Given this list of marker genes PSMB2, PAN3, BIRC6, TLR7, RANBP1, METTL15, H2AX, FRMD6, PIK3R5, SEMA4C, EZH2, ESCO2, LARP7, TBC1D32, ESYT3, SNX5, TCF4 (transcription factor 4), CA9, ZNF326, LSM6, MXD3, CBX2, FHOD3, TRIO, ERCC6L, SPC24, KCTD8, NSMCE1, GRIA2, N6AMT1, CDC25B, PSPH, DNMT3B, FGA, DLX1, NEK6, PADI4, RAC2, MAP7D1, NUTF2, CIT, MSRA, SLC25A39, RCSD1, LRRC40, ATXN10, SEMA3D, C4orf19, GALR1, HSD11B1, RASA4, RNF144A, MPEG1, RASA2, CD52, KPNA7, HLA-DMA, PRKDC, HMCES, OTOG, ITGB1BP2, SLCO3A1, SLFN5, ING3, POC1B, ANAPC15, BAIAP2, DHRS3, KNL1, IPCEF1, CASQ2, SLC9A9, CDK13, UMPS, GMIP, NTPCR, GAB3, CHRNA6, PYCARD, CTSS, TNFAIP1, ITGAL (integrin subunit alpha L), HYOU1, NPTXR (NCBI Gene Id 23467), ICOS, ELF3, C3orf52, MGAT5, MSRB3, PDGFRB, RAC3, SF3B4, STMN1, CEP72, SELPLG, TXNDC8, CENPN, MORN2, DTYMK (NCBI Gene Id 9102), DYNLL1, GM2A, LRRC26, ORMDL1, LIN9, FAM72A, CEBPA, DPY30, SHMT1, OXCT1, COX7A1, PTGER2, MPO, EIF3I, OSBPL5, FAM167A, ANKRD6, CD48, CTCF, HASPIN, TYROBP, MASTL, SERPINB1 (serpin family B member 1), LIMD2, IL17RA, SHLD1, KIF18A (NCBI Gene Id 81930), TUBA3C, TMED10, FLNB, NAA38, ARAP2, KIF23, RPL39, SBNO1, CCR7, NODAL, UBE4A, PDE7A, IL1R2, LGMN, PLAC8, PDSS1, SDC1, GPR65, FGF5, GLIPR1, FAM90A13, STING1, B9D2, PKMYT1 (NCBI Gene Id 9088), RNF168, API5, CCDC18, DGKI, NDUFC1, AKNA, LRP8, SNAP29, ZSCAN29, RPL18A (NCBI Gene Id 6142), IL21R, MFSD4A, CXXC4, MCM4, FEN1, CELA2A, TMEM87A (transmembrane protein 87A), MN1, CDC45, GTF2IRD1, CD96, KLHDC8A, IMPA2, SGO2, DYRK1A, GPR161, NUDT14, IVNS1ABP, EMB, PARPBP, RASAL1, BAZ1B, TREX1, BARHL1, NANS, ZFHX3, CENPO, OTULINL, PIF1, CDS1, PDAP1, TMEM107, CFP, FOXM1, HCN2, CLNK, IQGAP3, TM6SF1, COX5A, here is a description of the gene set: Genes down-regulated in plasmacytoid dendritic cells in response to CpG oligodeoxynucleotide 1826: 1h versus 4h. Human Gene Set: GSE7831_1H_VS_4H_CPG_STIM_PDC_DN from publication Iparraguirre A, Tobias JW, Hensley SE, Masek KS, Cavanagh LL, Rendl M, Hunter CA, Ertl HC, von Andrian UH, Weninger W (PMID 18029397) CpG 1826 binds to Toll-like receptor (TLR)9, whereas influenza virus PR8 activates pDC via TLR7. Differential stimulation of pDCs is expected to result in unique activation mechanism(s) leading to a different phenotypically and functionally matured pDC We used microarrays to detail the global programme of gene expression underlying the maturation process of pDC activated with CpG 1826 and influenza virus PR8. We identified a distinct expression profile of upregulated immunomediators. studied in species Homo sapiens